The following is a description of a gene set: Human Gene Set: HP_CONGENITAL_ICHTHYOSIFORM_ERYTHRODERMA Congenital ichthyosiform erythroderma An ichthyosiform abnormality of the skin with congenital onset. species: Homo sapiens, and this is the list of marker genes: KRT1, ERCC3, LORICRIN, STS, ASPRV1, KLK11, ALOXE3, EBP, ABHD5, CYP4F22, ELOVL4, PNPLA1, ALOX12B, KDSR, DBR1, TARS1, GTF2H5, KRT2, GJB2, ABCA12, SULT2B1, GJB6, TGM1, NIPAL4, CERS3, KRT10, GBA1, NSDHL, POMP, KRT16, ST14, ERCC2, SPINK5 (serine peptidase inhibitor Kazal type 5)